The following is a description of a gene set: part of: G-protein mediated events This event has been computationally inferred from an event that has been demonstrated in another species.<p>The inference is based on the homology mapping from PANTHER. Briefly, reactions for which all involved PhysicalEntities (in input, output and catalyst) have a mapped orthologue/paralogue (for complexes at least 75% of components must have a mapping) are inferred to the other species. Reactome Pathway: Adenylate cyclase activating pathway electronically inferred by orthology from the curated human pathway species: Mus musculus, and this is the list of marker genes: Adcy5, Adcy7, Adcy8